Given this list of marker genes DAB2IP, MAP3K3, DSG3, PTPN22, STK39, CAV3, HGF, SASH1, MAP3K5, DUSP1, GADD45A, PER1, RELL2, PHLPP1, RELL1, TREM2, OPRK1, IL1B, DUSP10 (dual specificity phosphatase 10), GADD45G, BMP2, MINK1, PJA2, ULK4, DLG1, MIR181B1, PRMT1, MIR181D, BMP4, CYLD, LGALS9, DSC2, AGER, ZC3H12A, MFHAS1, GDF6, EZR, MIR181A2, SPHK1, HAND2, SPI1, GADD45B (growth arrest and DNA damage inducible beta), LEP, MAP3K4, MIR20A, here is a description of the gene set: Any process that modulates the frequency, rate or extent of p38MAPK cascade. species: Homo sapiens Human Gene Set: GOBP_REGULATION_OF_P38MAPK_CASCADE